Given this list of marker genes Oga, Mlip, Smad3, Pparg, Errfi1, Atp2b4, Lmna, Foxo1, here is a description of the gene set: Mouse Gene Set: GOBP_NEGATIVE_REGULATION_OF_CARDIAC_MUSCLE_ADAPTATION Any process that decreases the rate, extent or frequency of the process in which cardiac muscle adapts, with consequent modifications to structural and/or functional phenotypes, in response to a stimulus. Stimuli include contractile activity, loading conditions, substrate supply, and environmental factors. studied in species Mus musculus